Given this list of marker genes Stxbp1, Abat, Htr6, Kcnj8, Avpr1a, Folr1, Bdnf (NCBI Gene Id 12064), Dtnbp1, Slc25a13, Slc3a1, Slc7a11, Grin2b, Slc19a3, Epm2a, Tnf, Ucp2, Prkg1, Slc19a1, Rab3gap1, Slc25a32, Slc7a13, Grm1 (glutamate receptor, metabotropic 1), Grm7, Slc46a1, Lrrc8e, Slc13a5, Hrh3, Slc1a3, Abcc2, Prkcd, Best1, Pdpn, Lrrc8d, Lrp2, Slc12a2, Slc1a1, Slc16a1, Cln8, Abcc8, Cck, Syt4, Kmo, Grm2, Pak1 (p21 (RAC1) activated kinase 1), Arl6ip1, Slc22a7, Avp, Adora2a, Gfap, Kcnj10, Lrrc8c, Slc26a8, Slc38a6, Vps54, Itgb1, Slc26a5, Gnat2, Slc26a11, Apba1, Abcc5, Slc25a10, Trpv1, Il1rn, Snca, Slc17a8, Arl6ip5, Gipc1, Gja1, Grik1, Trh, Ntsr1, Ntrk2, Slc1a4, Slc17a6, Pianp, Slc25a22, Slc1a5, Gabbr1, Slc25a12, Slc13a2, Ttyh3, Slc26a7 (solute carrier family 26, member 7), Per2, Slc38a2, Slc1a7, Slc25a18 (NCBI Gene Id 71803), Slc1a2, Slc22a6, Slc13a3, Ttyh2, Adora1, Ttyh1, Slc26a1, Septin2, Nf1, Psen1, Lrrc8a, Slc1a6 (NCBI Gene Id 20513), Slc25a21 (solute carrier family 25 (mitochondrial oxodicarboxylate carrier), member 21), Myo6, Npy5r, Slc25a11, Nr3c1, Slc17a7, Kcnk1, Kcnk2, Agxt, Arhgef11, Folr2, Il1b, Lrrc8b, Slc26a6, P2rx7, Dpysl2, here is a description of the gene set: The directed movement of dicarboxylic acids into, out of or within a cell, or between cells, by means of some agent such as a transporter or pore. studied in species Mus musculus Mouse Gene Set: GOBP_DICARBOXYLIC_ACID_TRANSPORT